The following is a description of a gene set: The division of the cytoplasm and the plasma membrane of a cell and its partitioning into two daughter cells. studied in species Homo sapiens Human Gene Set: GOBP_CYTOKINESIS, and this is the list of marker genes: TRIM36, SEPTIN7, ZFYVE19, SETD2, SNX9, RHOB (NCBI Gene Id 388), CIT, RHOC, OPN1MW2, CDC42, STAMBP, OR1A2, ARF6, EXOC4, EXOC1, CNTROB, SEPTIN1, MTMR3, CALM1, AURKB, DRD2, NUSAP1, AURKA, ENTR1, ARF1, TAS1R2, DCTN3, PKP4, CDC6, SEPTIN8, KLHL21, CHMP5, CHMP2A, KIF14, ZFYVE26, KIF20B, CALM3, DCDC1, TAS2R13, CHMP4A, EXOC7, AURKC, KIF4B, CETN2, RAB11FIP4, DRD3, CENPA, ANXA11, VPS4B (NCBI Gene Id 9525), E2F8 (NCBI Gene Id 79733), KLHDC8B, PLK1, BCL2L1, APC, LUZP1, EXOC8 (NCBI Gene Id 149371), PLEC, ARL3, IQGAP1, ROCK2, OR2A4, ZNF365, UVRAG, LZTS2, SPART, RAB11A, ACTR2, CDCA8 (NCBI Gene Id 55143), GIT1, SEPTIN10, OPN1LW, SPIRE2, TTC19 (NCBI Gene Id 54902), SHCBP1L, POLDIP2, PDCD6IP, EXOC6, KLHL13, NOX5, SEPTIN4, CHMP1B, ACTR3, CHMP7, CFL1 (NCBI Gene Id 1072), RHOA, ROCK1 (Rho associated coiled-coil containing protein kinase 1), PIN1, RAB35, CENPV, MYH10, NUP62, CCDC66, RACGAP1, PLK3 (polo like kinase 3), KIF13A, ORC4, ANK3, CDC14C, SEPTIN9, CSPP1, SEPTIN2, VPS4A, PIK3C3, STMN1, FSD1, SEPTIN5 (NCBI Gene Id 5413), AHCTF1, PRKCE, CALM2, CHMP4BP1, RAB11FIP3, MTMR4, WNK1, MYH14, IQGAP2, MITD1, CHMP4C, E2F7, SEPTIN12, BIRC5, MAP9, GIPC1, CCP110, EFHC1, JTB, KLHL9, RXFP3, INCENP, PKN2, CEP55, TEX14, KIF20A, ANKRD53, SH3GLB1, ESPL1, EXOC2, BRCA2, UNC119, CHMP2B, PRC1, OPN1MW, SEPTIN11, ANLN, SON, CHMP6, RASA1, SSTR5, CHMP1A, WASHC5 (NCBI Gene Id 9897), CECR2, SPAST, IST1, IQGAP3, CUL7, MYH9, ATXN10, KIF3B, CUL3 (cullin 3), KIF23, MAP10 (NCBI Gene Id 54627), CKAP2, ALKBH4, SEPTIN6, CDC14B, CHMP4B, FMN2, SEPTIN3, MYO19, CHMP3, EXOC6B, BIN3, PDXP, SPIRE1, PIK3R4, SEPTIN14, MRGPRX2 (NCBI Gene Id 117194), SNX18, PRPF40A, CDC25B, SNX33, ECT2, KIF4A, ROPN1B, USP8, CDC14A, RTKN, SPTBN1, CXCR5, EXOC3, EXOC5, BECN1, BBS4, BIRC6, SVIL